The following is a description of a gene set: species: Homo sapiens Solute carrier (SLC) genes that code chloride (Cl-)/bicarbonate (HCO3-) exchanger proteins are in the SLC4 and SLC26 families. SLC26A4 (pendrin) is thought to act as a chloride/anion exchanger but in the thyroid and inner ear, it also contributes to the conditioning of the endolymphatic fluid by mediating iodide (I-) transport. Defects in SLC26A4 can cause Pendred syndrome (PDS; MIM:274600), an autosomal recessive disorder characterised by congenital sensorineural hearing loss in association with thyroid goiter. Reactome Pathway: Defective SLC26A4 causes Pendred syndrome (PDS) part of: SLC transporter disorders, and this is the list of marker genes: SLC26A4